Given this list of marker genes FOSB, CYP2B7P, SLC22A3, DOCK5, FTCD, PROZ, KIFC3, NSUN6, ZFAND5, LINC01554, SLC25A18, B2M, NCOA2, CFHR3, SRSF4, LEPR, CDK13, LRRFIP2, SLC20A1, SLC39A14, HGFAC, KANSL1, FCN3 (ficolin 3), SLX4IP, TMEM178A, SMIM14, DPYS (dihydropyrimidinase), RORA, PIK3R1, UBE2B, B4GALT1, CYP4A11, MUC20, GSDMB, NBPF11, GLS2, BACH2, DUSP16, ARNT, ARHGEF1, CP, IDO2, MBNL2, SMURF1, MAP3K13, PLG, LMO7, ABCA9 (ATP binding cassette subfamily A member 9), TPCN2, EGR1, F11, SERPINB9, RAPGEF2, BHMT, GPAT3, CPEB4 (cytoplasmic polyadenylation element binding protein 4), TNFSF14, LURAP1L, HSPD1, HSDL2, LPA, CYP1A2 (cytochrome P450 family 1 subfamily A member 2), SORL1, SLC25A47, PITPNB, ID2, TNRC6A, THBS1, ETS2, PALM3, SIK3 (SIK family kinase 3), TRIR, CYP2C19, CYP2A7, MARVELD2, GSAP, ARMC8, ACOX1, NAMPT, PCSK6, WWC1, SORBS2, ARHGEF10L, ELL2, LRP6, RNF125, here is a description of the gene set: Human Gene Set: CHIANG_LIVER_CANCER_SUBCLASS_UNANNOTATED_UP species: Homo sapiens Hepatocellular carcinomas represent the third leading cause of cancer-related deaths worldwide. The vast majority of cases arise in the context of chronic liver injury due to hepatitis B virus or hepatitis C virus infection. To identify genetic mechanisms of hepatocarcinogenesis, we characterized copy number alterations and gene expression profiles from the same set of tumors associated with hepatitis C virus. Most tumors harbored 1q gain, 8q gain, or 8p loss, with occasional alterations in 13 additional chromosome arms. In addition to amplifications at 11q13 in 6 of 103 tumors, 4 tumors harbored focal gains at 6p21 incorporating vascular endothelial growth factor A (VEGFA). Fluorescence in situ hybridization on an independent validation set of 210 tumors found 6p21 high-level gains in 14 tumors, as well as 2 tumors with 6p21 amplifications. Strikingly, this locus overlapped with copy gains in 4 of 371 lung adenocarcinomas. Overexpression of VEGFA via 6p21 gain in hepatocellular carcinomas suggested a novel, non-cell-autonomous mechanism of oncogene activation. Hierarchical clustering of gene expression among 91 of these tumors identified five classes, including CTNNB1, proliferation, IFN-related, a novel class defined by polysomy of chromosome 7, and an unannotated class. These class labels were further supported by molecular data; mutations in CTNNB1 were enriched in the CTNNB1 class, whereas insulin-like growth factor I receptor and RPS6 phosphorylation were enriched in the proliferation class. The enrichment of signaling pathway alterations in gene expression classes provides insights on hepatocellular carcinoma pathogenesis. Furthermore, the prevalence of VEGFA high-level gains in multiple tumor types suggests indications for clinical trials of antiangiogenic therapies. from publication Chiang DY, Villanueva A, Hoshida Y, Peix J, Newell P, Minguez B, LeBlanc AC, Donovan DJ, Thung SN, Solé M, Tovar V, Alsinet C, Ramos AH, Barretina J, Roayaie S, Schwartz M, Waxman S, Bruix J, Mazzaferro V, Ligon AH, Najfeld V, Friedman SL, Sellers WR, Meyerson M, Llovet JM (PMID 18701503) Marker genes up-regulated in the 'unannotated' subclass of hepatocellular carcinoma (HCC) samples.